Given this list of marker genes Wdfy3, Olfml1, Ppp4r3a, Srsf7, Atf2, Nt5c2 (5'-nucleotidase, cytosolic II), Itga9, Cyb561a3, Mef2a, Ubl3, Adamts15, Ammecr1, Erlin2, Igsf3, Ell2, Slc7a15, Cdcp2, Rnf170, Cfap97, Xpnpep3, Fam163a, Pde2a, Txndc5, Dnajc25, Ppp1r16b, Camsap2, Asap2, Rpp14, Kir3dl1 (NCBI Gene Id 245616), Ppp1r3d, Zfp945, Tnrc6b, Hacd2, Myt1l, Fmn1, Fign, Msra, Nkain2, Dock5 (dedicator of cytokinesis 5), Ptpn2, Suco, Itpripl2, Fam43b, Khdc4, Ubtd1, Anks6, Nr2c2, Ino80d, Nebl, Irx1, Fzd1, Prdm16 (NCBI Gene Id 70673), Sufu, Cd300lg, Eva1a, Il10ra (interleukin 10 receptor, alpha), Zfp609, Loricrin, Ube2b, Immt, Slc2a10, Hs3st3b1, Glud1, Yy2, Rpgrip1l, Fam98a, Psen2, Cds2, Adam7, Epha4, Rap1gds1, Pde8a, Slc45a4, Hace1, Ttyh2, Zfr, Spink6, Gvin1, Slc40a1, Sytl4, Myh4, Dst, Rnf17, Adgrf5, Neurl1a, Eya1, Reep1, Rdh1, Cpeb4, Nadk2, Map2k4, Syn3, Sema5a, Gvin2, Etv1, Pacs2 (NCBI Gene Id 77149), Camta1, Cnot7, Hic2, Amotl1, Tpd52l2, Adam22, Kctd9, Rab3b, Podn, Htt, Rp1l1, Clic5, Spin4, Tmem38b, Ttll12, Ankrd10, Rnf111, Fut10, Clpb, Paip2, Rbl1, Trub2, Dner, Wsb1, Il1r1, Dip2b, Zfp729b, Usp9x, Oga (O-GlcNAcase), Sntg1, Arhgap17, Nrcam, Pwp2, Fcer1a, Noc2l, Klk7, Rap2c, Lrrc14, Pkm, Stk3, Slc12a7, Maea, Sh3pxd2a, Ston2, Slc35f6, Rab30, Mfsd3, Glmp, Pknox1, Serpina1f, Gabbr2 (gamma-aminobutyric acid type B receptor subunit 2), Poldip2, Ccdc126, Pappa, Wdr47, Samd11, Plekhf2, Dnajc28, Agtpbp1, Enc1, Ppm1f, Slco5a1, Myorg, Rpl13a, Cdh17, Nipbl, Sumf2, Col12a1, Plch1, Btbd3 (NCBI Gene Id 228662), Lin7a, here is a description of the gene set: from publication Chen Y, Wang X (PMID 31504780) studied in species Mus musculus Genes predicted to be targets of miRBase v22 microRNA mmu_miR_12201_3p in miRDB v6.0 with MirTarget v4 prediction scores > 80 (high confidence targets). Mouse Gene Set: MIR_12201_3P